Given this list of marker genes CASP3, CMTM4, YTHDC1, SYNPO2, GSPT1, SACM1L, YTHDF3, UBE2W (ubiquitin conjugating enzyme E2 W), ZFP36, ATAD2B, BRINP3, GK5, FLT1, CNTLN, APOLD1, PIEZO2, DLD, IGDCC4, PHF2, GTF2B, RNPS1, DAAM1, MAML1 (NCBI Gene Id 9794), SALL3, EIF5A2, CRHBP, DENND1B, ANKRD17, PTPRR, HOOK3, MYO16, MARCHF6, SECISBP2L, LHFPL2, FUCA2, ABHD3, TTC28, ZFHX3, SEPTIN14, RB1, MYT1L (myelin transcription factor 1 like), ZNF148, MACIR, DICER1, ZBTB49, SLC4A4, KLF7, SRSF10, DEPTOR, PLCL1, SDC2, BSDC1, TCF7L2, RAP1B, BEND4, HECTD2, KDM6A, FGF14, CD8A, VPS54, ACAD11 (acyl-CoA dehydrogenase family member 11), RASSF8, ZMYM2, CNOT7, ERBB4, ODC1, CDKN1B, ZNF616, CLVS2, MAPKAP1, TMEM87A, SEC62, ZNF385B, SUN2, RALGAPA1, TRABD2B, FAM53B, MYLIP, TCF12, LSM14A, EIF2AK3, PRKCH, IPO7, NDUFB5, ZNF704, TP53BP2, TMEM165, GATA5 (GATA binding protein 5), RBPJ, AADACL2, HNRNPA0 (NCBI Gene Id 10949), ZNF326, RUNX2, HDGF, SCD5, RGS7 (regulator of G protein signaling 7), PPP2R2A, RNF44, CALHM4, TNRC6C, SMOC1, GBE1, ARHGEF7, NBEA, PTPRZ1, RANBP2, TGFBR1, COPS2, TBC1D22B, BTBD3, RIMS3, FBXO22, U2SURP, CDH2, NCKAP5, LRRN1, SLC25A21, RFX3, NUP35, PSAP, TMPRSS3, CPSF6, DMRT3, FAM193A, SALL4, PAIP1, MMD2 (monocyte to macrophage differentiation associated 2), AIDA, ATP1B1, CRTAP, TFAP2A, DDIT4, YAF2, ATXN1, GNB1, SNAP25, TEAD1, PCDH9, CPEB4, SLC26A3, TMEM132C, MKI67, MIER3, TOX, SOX11, ADIPOR1, CYLD, E2F2, ZNF805, MARK1, UBE2E3, DYNC1I1, SYNCRIP, FER, MON2, SMARCA2, SLITRK5, DCAF7, PHF12, PDIK1L, PEX1, SLC4A7, TTF2, DCLK1, THSD7B, GABRA1, FRS2 (NCBI Gene Id 10818), SEMA4G, here is a description of the gene set: from publication Chen Y, Wang X (PMID 31504780) Human Gene Set: MIR187_5P Genes predicted to be targets of miRBase v22 microRNA hsa-miR-187-5p in miRDB v6.0 with MirTarget v4 prediction scores > 80 (high confidence targets). studied in species Homo sapiens